The following is a description of a gene set: species: Homo sapiens Human Gene Set: GOBP_PROTEIN_LIPID_COMPLEX_ORGANIZATION Any process in which macromolecules aggregate, disaggregate, or are modified, resulting in the formation, disassembly, or alteration of a protein-lipid complex., and this is the list of marker genes: SNX9, DGAT1, APOE (apolipoprotein E), PNLIPRP3, APOC3, PNLIP, APOA2, PLA2G7, PNLIPRP2, CETP, APOM, ZDHHC8, PLAGL2, PCSK5, ABCA1, AGT, MFSD2A, PLA2G2A, GPIHBP1, PCDHGA3, MPO, LPCAT3 (NCBI Gene Id 10162), APOA4, SCARB1, SOAT1, ABCA7, PRKACB, PCSK6, NR1H4, LIPC, PLA2G2E, APOC2, PRKACA, ABCA5, PLA2G5, PNLIPRP1, ANGPTL3, ANGPTL4, NR1H2, PRKACG, APOC1, MIR144, APOH, BIN1, LIPG, SOAT2, PLA2G3, FURIN, LCAT, APOA5, APOB, MTTP, PON1, ACSL3 (NCBI Gene Id 55484), AGTR1, PLTP, APOA1, FECH, PLA2G10, ABCG1, CIDEB, LPL